The following is a description of a gene set: Mouse Gene Set: GOMF_OXIDOREDUCTASE_ACTIVITY_ACTING_ON_THE_CH_CH_GROUP_OF_DONORS species: Mus musculus Catalysis of an oxidation-reduction (redox) reaction in which a CH-CH group acts as a hydrogen or electron donor and reduces a hydrogen or electron acceptor., and this is the list of marker genes: Acads, Dus1l, Sdhd, Acadvl, ENSMUSG00000144291, Acad9, Tecrl, Blvrb, Tbxas1, Akr1b1, Rsad1, Cyp2s1, Cpox, Ptgr2, Srd5a1, Lbr, Ppox, Acad11, Bdh2, Dus2, Sdha, Akr1d1, Pecr, Acad10, Ptgr3 (prostaglandin reductase 3), Dhodh, Dhcr24, Akr1c14, Ivd, Akr1cl, Crat, Akr1c20, Acaa1b, Acox2, Dhcr7, Akr1c18, Ptgr1, Dus3l, Gcdh, Srd5a3 (NCBI Gene Id 78351), Acox3, Acadm, Dpyd, Mecr, Tm7sf2, Ptges2 (NCBI Gene Id 96979), Dhdh, Tecr, Acox1, Dus4l, Fasn, Acadl, Blvra, Sdhb, Acad8, Acoxl, Acaa1a, Srd5a2, Decr2, Acadsb, Cox15, Retsat, Acad12, Akr1c6, Akr1c21, Decr1